The following is a description of a gene set: A process which maintains the organization and the arrangement of proteins in the presynaptic specialization. species: Mus musculus Mouse Gene Set: GOBP_MAINTENANCE_OF_POSTSYNAPTIC_SPECIALIZATION_STRUCTURE, and this is the list of marker genes: Ophn1, Prickle2, Dgkz, Arf6, Hspa8, Dlg1, Csmd2, Syngap1, Adgrl3, Cadm1, Rapsn, Itgb3, Shank1, Itgb1, Mpp2, Prickle1, Dlg2, Shank3